The following is a description of a gene set: species: Homo sapiens An abnormal concentration of sodium in the urine. Human Gene Set: HP_ABNORMAL_URINE_SODIUM_CONCENTRATION Abnormal urine sodium concentration, and this is the list of marker genes: MC2R, TXNRD2, HSD11B2, CLCNKA, CYP11B2, KCNJ10, GATM (NCBI Gene Id 65211), STAR, SEC61A1, MRAP, CYP11A1, AVPR2, NNT (nicotinamide nucleotide transhydrogenase), SLC34A1, NDUFAF6, BSND, EHHADH, CLCNKB